Given this list of marker genes ENDOG, LIN28A, MAPK13, NOX4, GCLC (NCBI Gene Id 2729), BRSK2, COL1A1, SMAD3, GHRL, GPX1, SLC26A6, GPR27, TUNAR, GCLM, CLTRN, UNC13B, PDE8B, UBTF, CLEC7A, MIR320D1, RAF1, PRKCE, SLC12A6, SLC2A5, RACK1, KLF7, ERN1, KCNK16, AGER, HIF1A, MLXIPL, SLC9B2, TRA2B, ZNF236, KCNB1, JAGN1, PPARA, PHPT1, RPS6KA2, ENY2, SELENOT, CYBA, EPHA5, ADRA2A, ICAM1, PRKN, MIR15A, MPC2, HLA-DRB1, PIH1D1, ABCC8, ZBED6, SIDT2, SRF, IGF1R, FKBP1B, NKX6-1, CRH, GAS6, GATA4, RPTOR, ANO1, RBM4, RAC1, MIR16-1, KAT5, RAB11FIP2, MIR320B1, ZBTB20, PPARD, NR1H4, TGFB1, NCF1, SIN3A, FIS1, SMAD4, GJB6, CASR, FUT1, BAIAP3, CDK16, SMARCB1, PCK2, GPLD1, MAP2K3, SOX4, MIR320A, NDUFAF2, SRI, GPR68, OXCT1, STX4, MIRLET7G, DYNLL1, MIR146A (NCBI Gene Id 406938), PLCB1, CCDC186, XBP1, TRPM4, MIR320C2, ABCA12 (ATP binding cassette subfamily A member 12), PCK1, NPTX1, TRPM5, OSBP, CYP7A1, SERPINF1, PTPRN, CFTR, USF2, SLC2A2, RFX6, CALCRL, RAB11FIP5, SLC29A1, ZFP36L1, PPP3CB, COLEC12, BAD, OGT, IRS2, EFNA5, NADK, PRKAA2, TREM2, IGF1, ADCY5, SLC12A7, NR1D1 (nuclear receptor subfamily 1 group D member 1), MIR320B2 (NCBI Gene Id 100313769), RAB11B, PTPRN2, SLC39A14, TRPA1, GHRHR, UCP2, FOXO3, CMA1, PDX1, MIR320E, FBP1, PRKCB (NCBI Gene Id 5579), PLA2G6, SMARCA4, GPRC6A, LEP, OPRK1, C1QTNF12, FOXA2, MIR320D2, MIR320C1, STXBP4, MIR337, ADCY8, PRKACA, GPER1, SYBU, VSNL1, PIM3, USF1, LRP5, C2CD2L, PAX2, PRKAA1, PIK3CA, GCG, here is a description of the gene set: Human Gene Set: GOBP_CELLULAR_RESPONSE_TO_CARBOHYDRATE_STIMULUS Any process that results in a change in state or activity of a cell (in terms of movement, secretion, enzyme production, gene expression, etc.) as a result of a carbohydrate stimulus. species: Homo sapiens